Given this list of marker genes PLA2G6, DGCR2, PPOX, TP53, IMPA1, USP8, CDH23, TIMM8A (translocase of inner mitochondrial membrane 8A), FMO3, HMBS, SNCA, PRDM8, USP48, BRAF, TBP, NR3C1, CPOX, ESS2, DGCR6, TBX1, ATRX, VPS13A, ECM1, DGCR8, here is a description of the gene set: The feeling and belief that one is being targeted or is a focus of negative or untoward actions, overt or covert, from others. The affected individual expresses a concern that people are in general against the individual and are engaging in subtle behaviors to make things difficult for them. The origins of such thinking may arise from real events and become amplified over time. Paranoia may also arise in the absence of any action or interaction between the person and their environment. Human Gene Set: HP_PARANOIA Paranoia species: Homo sapiens